The following is a description of a gene set: species: Homo sapiens Human Gene Set: HP_ABNORMAL_NASAL_SKELETON_MORPHOLOGY An abnormality of the nasal skeleton. Abnormal nasal skeleton morphology, and this is the list of marker genes: UBA1, PDGFRB, PTCH1, BRAF, CTNNB1, PPP1R12A (protein phosphatase 1 regulatory subunit 12A), ALX4, TGIF1, TONSL, SIX3, USH1G, SLC25A24